The following is a description of a gene set: Mouse Gene Set: GOBP_RENAL_ABSORPTION species: Mus musculus A renal system process in which water, ions, glucose and proteins are taken up from the collecting ducts, glomerulus and proximal and distal loops of the nephron. In non-mammalian species, absorption may occur in related structures (e.g. protein absorption is observed in nephrocytes in Drosophila, see )., and this is the list of marker genes: Umod, Ang2, Amn, Mllt6 (NCBI Gene Id 246198), Dab2, Nherf1, Cldn16, Rhpn1, Cldn4, Guca2b, Maged2, Clcnkb, Adipoq (adiponectin, C1Q and collagen domain containing), Hyal2, Gsn, Cd2ap, Slc15a2 (NCBI Gene Id 98014), Has2, Klhl3, Hnf1a, Slc6a18, Slc5a2, Kcnq1, Ednrb, Slc5a1, Gas6, Wnk4, Kirrel1, Slc12a3, Stk39, Sctr, Edn1, Comt, Aqp3, Aqp4, Ednra, Ctns, Oxsr1, Aqp7, Kcnj1, Aqp1, Cldn19